Given this list of marker genes Dennd1b, Vsir, Cd80, Zp3, H2-T13, Cd274, Cd24a, H2-M3, Hspa8, Il18, Mr1, Pvr, Rsad2, Raet1e, Tnfsf4, Azgp1, Cd55b, H2-M2, Nectin2, H60b, Nlrp3, Pdcd1, H60c, Slc22a13, Ccl20, Ufl1, H2-Q7, Il12b, H2-M10.1, H2-D1, Clec4g, Il20rb, H2-M9, Cd1d1, Smad7, Fbxo38, Was, H2-Q1, 2410137M14Rik, Cd81, Dpp4, Ripk3, Stx7, Nod2, Ywhag, Prkaa1, Ulbp1, Xcl1, Ager, H2-K1, B2m, H2-M1, H2-Q10, Il6, Il23a (interleukin 23, alpha subunit p19), Il1b, H2-M10.2, H2-M5, Muc4 (mucin 4), Il4i1, Malt1, H2-M11, Prkcz, Il7r, Raet1d, H2-T5, Cd1d2, Spn (NCBI Gene Id 20737), Slamf1, Tnfrsf1b, Tbx21, Ifnb1, Tap2, Ppp3cb, H2-M10.6, H2-M10.3, Hmgb1, Ceacam1, Arg1, H2-T3, H2-M10.4 (histocompatibility 2, M region locus 10.4), Arid5a, Fadd, Ptprc, H2-T22, Klhl22, Cyrib, Zbtb1, Il1r1, P2rx7, Traf2, Lilrb4a (leukocyte immunoglobulin-like receptor, subfamily B, member 4A), Map3k7, H2-T15, Il12a, Il18r1, H2-T23, Traf6, Ccr2, H2-Ea, Hspd1, Foxp3, Sash3, Hfe (NCBI Gene Id 15216), Gata3, Klrd1, Lilrb4b (NCBI Gene Id 14727), Il4, H2-T24, Nckap1l, Pnp, Fzd5, Dusp22, H2-Q2, Ahr, H2-Q6, Cd55, H2-M10.5, H2-Q4, Fut7 (NCBI Gene Id 99110), Trpm4, here is a description of the gene set: Mouse Gene Set: GOBP_REGULATION_OF_T_CELL_MEDIATED_IMMUNITY species: Mus musculus Any process that modulates the frequency, rate, or extent of T cell mediated immunity.